Given this list of marker genes Cad, here is a description of the gene set: part of: Nucleotide biosynthesis Reactome Pathway: Pyrimidine biosynthesis This event has been computationally inferred from an event that has been demonstrated in another species.<p>The inference is based on the homology mapping from PANTHER. Briefly, reactions for which all involved PhysicalEntities (in input, output and catalyst) have a mapped orthologue/paralogue (for complexes at least 75% of components must have a mapping) are inferred to the other species. electronically inferred by orthology from the curated human pathway studied in species Mus musculus